The following is a description of a gene set: Mouse Gene Set: HOWLIN_PUBERTAL_MAMMARY_GLAND from publication Howlin J, McBryan J, Napoletano S, Lambe T, McArdle E, Shioda T, Martin F (PMID 16278680) Expression microarray analysis identified CITED1 among a group of genes specifically upregulated in the pubertal mouse mammary gland. At puberty, CITED1 localizes to the luminal epithelial cell population of the mammary ducts and the body cells of the terminal end buds. Generation of CITED1 gene knockout mice showed that homozygous null mutants exhibit retarded mammary ductal growth at puberty and, in addition, dilated ductal structures with a lack of spatial restriction of the subtending branches. Analysis of CITED1 homozygous null and heterozygous null mammary gland gene expression using microarrays suggested that the mammary-specific phenotype seen in the homozygous null females is due to a disturbance in the transcription of a number of key mediators of pubertal ductal morphogenesis. These include estrogen and TGFbeta responsive genes, such as the EGFR/ErbB2 ligand, amphiregulin, whose transcription we suggest is directly or indirectly regulated by CITED1. Genes up-regulated in pubertal mammary glands compared to mammary glands from other developmental stages. species: Mus musculus, and this is the list of marker genes: Hsd11b1, Pten, Prrx2, Gsta3, Lsp1, Dbp, Slc6a6 (NCBI Gene Id 97306), Tnf, Col18a1, Idi1, Reck, Penk, Krt10, Cfh, Evi2a, Ear1, Ifi207, Ptn, Nfil3, Angptl2, Apbb1ip, Ctsb, Calm4, Krtap6-2, Slc30a1, Cxcl12, Twist1, Pi4ka, Fcrla, Hal, Ngp, Mycl, Nat8f2, Foxa1, Prom1, Ccl6, Pck1, Rsph3b, Cyp4b1-ps2, Pdgfra, Limd2, Eps15, S100a9, Krtap6-3, Klf4, Npy6r, 2310010J17Rik, Cpxm1, Vegfd, Inhbb, Sprr2a1, Npr3, Eps8, Cited1, Sfrp4, Il1r2, Tdrp, Reg3b, Elovl6, Aox1, Cyp4v3, Vpreb3, Comt, Apod, Areg, Ccl7, Thbs2, Marco, Sms, Fcgr2b, Ccl8, Msr1 (NCBI Gene Id 20288), Ighv2-4